Given this list of marker genes NRG3, NLGN4X, TAOK2, NPHP1, PDZD11, CDH22, ABI3, CLDN16, PIP5K1C, SFRP1, EPHA7, HTR4, DST, DLC1 (DLC1 Rho GTPase activating protein), NLGN3, RELN, DRD1, CC2D1A, GPBAR1, ADGRB3, LIN7C, DSG1, C1QL2 (complement C1q like 2), CLASP1, WDPCP, SRGAP2C (NCBI Gene Id 653464), PTK2, PTPN13, POF1B (POF1B actin binding protein), FLRT1, CDH18, DOCK10, DSCAM, CLDN22, NTRK1, TNS1, EPHB2, GABRA1 (NCBI Gene Id 2554), PPM1F, ERBB4, PLXNB2, RAC3, RAP1A, ADGRB2, OPHN1, SRGAP2B, BSN, SMAD3, NPTN, CTNNA1, RAPGEF1, LAMA3, GJA5, SLITRK2, ADGRL2, SLITRK4, S100A10, LIM2, FLRT3, ASIC2, CDH15, KDR, TJP1, GNA13, MIR431, CTNNB1, GABRA6, NPTX1, JAM3, CLDN17, SEMA4D, LIMS1, ADGRB1, PLXNA1, ECT2, TBX5, ANK2, ARHGAP33, PCDHB5, PEAK1, PCDHB16, MYO9A, COL17A1, CLDN2, DBNL, LRIT3, ARHGEF9, SLITRK1, DSG3, CLDN19, NRCAM, VSTM5, ARHGEF15, PPP1R9B, CORO1C, LRRC4B, CLDN11, GPM6B, MARVELD3, NTNG2, SLITRK5, CDC42, GJB1, CD9, PLXNA2, GJA4, GABRA3, CDH2, MIR142, CDH12, CLDN5, MPDZ, FLOT1, FLCN, TLN2, PLXNA3, EPHB3, MYO1C, FKRP, CBLN4, PKP4, GHSR, PTPRK, CAPRIN1, ROCK1, TNF, ACTN1, MMP14, SNCA (NCBI Gene Id 6622), ST8SIA2, RAMP2, RHOG, SPTBN2, FZD5, TSC1, FN1, DOCK4, FAM107A, CLDN8, NCKIPSD, UBE3B (NCBI Gene Id 89910), OCLN, CHD4, PKP3, VEGFA, LRRTM1, SYNDIG1, CNTNAP1, LRRTM3, ZDHHC12, S1PR2, CLDN20, GABRA2, IL1RAPL2, CDH11, CNTN5 (NCBI Gene Id 53942), PARD6B, CLDN23, SRPX2, SLK, FER, MAP1B, GNPAT, NPAS4, PKP2, CNTNAP2, BCR, NRXN1, SH3BP1, MAP4K4 (mitogen-activated protein kinase kinase kinase kinase 4), SORBS1, SPOCK2, GJC1, UGT8, PIP5K1A, TLR2, GABRG3, LIN7B, SLC25A46, EEF2K, ITGB1BP1, PRKACA (protein kinase cAMP-activated catalytic subunit alpha), GJA1, ITGA5, VSIG10, CLDN15, NPHP4, SENP1, LIN7A, GJD3, CLDN25 (claudin 25), C1QL3, GJA10, BDNF, GRM6, ASIC1, CBLN1, PECAM1, PTPRJ, CASKIN1, LRFN3, VCL, THSD1, CDH5, WNT3A, CDH4, APP, CLDN6, GABRB2, SIX4, NTN1, CSMD2, SHANK2, COL16A1, IRX3, IL1RAP, POU4F1 (POU class 4 homeobox 1), CUX2, ACTG1, HIPK1, DUSP22, RAP2A, FSCN1, TEK, OGT, SRF, ABL1, DUSP3, ACTB, PUM2, PTK2B, GABRG1, FZD1, NRP1, ELFN1, NTRK3, PLXND1, CLDN7, RAC1, IL1RAPL1, CDH6, RYK, STON1, MACF1, CFL1, CLDN14, ARHGAP6, CRKL, LINGO4, CLDN4, SNAI2, RTN4 (reticulon 4), NRXN2, MARVELD2, ITGA2, FGF13, AFDN, SLITRK6, MYOC, STRN, SDK1, PTPRA, ACTN2, CLDN34, PCDHB11, NLGN2, CLDN9, GPHN, HRG, PCDHB2, SLIT1, CLSTN3, CAPZA1, PTPRO, F11R, IL1B, GREM1, IQSEC2, CLSTN2, DAPK3, LRRC24, ADD2, MARK1, ACHE (NCBI Gene Id 43), LSR, CLDN10, GPM6A, RAP1B, FBXO45, PTPN1, CLASP2, DKK1, LRRN3, PTEN, DNER, ICAM5, NTRK2, SLITRK3, ACE2, CTTN, MEF2C, CARMIL3, LRP4, TRIP6, AMOT, DMTN, PHLDB2, WHAMM, EFNA5, PCDHB4, TESK2, RAB13, VLDLR, FBF1, ARMCX5-GPRASP2, CDH24, PDCD6IP, EPHA3, LZTS1, EIF4G1, SEMA4A, SEMA4C, CLDN1, SHANK3, NEURL1, SMAD7, GRHL2, CDH3, AJUBA, CAMSAP3, NPHS1, PLXNA4, SLC9A1 (solute carrier family 9 member A1), RPS6, MPP7, CLDN3, CRK, MUSK, SLC39A9, MDGA1, GDF2, VMP1, LRRTM2, LATS1, CDH20, LRRN1, CDK5, CDH19, PLXNC1, WNT7A (Wnt family member 7A), PCDHB6, ITGB4, DVL1, ZDHHC2, FERMT2, LDB1, GAP43, GPRASP3, IKBKB, TBCD, GABRB3, CLDN18, TRPV4 (transient receptor potential cation channel subfamily V member 4), HAPLN4, SRC, NEGR1, RCC2, APLNR, RHOA, MAPT, BCL2, UBE2M, SDC4, GRIA1, NECTIN1, IL17A, GABRE (NCBI Gene Id 2564), ADNP, PTPRD, ROBO2, CRTAC1, GRID2, LIMCH1, APC, CDH13, THBS2, SETD5 (NCBI Gene Id 55209), HDAC7, DRD2, PLXNB3, PLXNB1, MICALL2, LRTM2, VPS35, POLDIP2, SNAI1, EFNB2, ZDHHC8 (NCBI Gene Id 29801), GJB2, RTN4R, STAU2, GPC4, SIX1, PCDHB3, NUMBL, DLG1, CAV1, DOCK1, PLEC, RAB17, MYCBP2, ARL2, LHFPL4, WNT4, CYFIP2, GABRG2, ARHGAP12, DNM3, PRKCH, RAPGEF2, APOD, MIR105-1, NEDD8, THBS1, FRMPD2, WDR1, ADGRL3, ARF6, PKP1, ACTN3, PTPRS, LRFN4, PCDHB9, ESAM, CDH1 (NCBI Gene Id 999), ACE, LGI2, GABRA5, CLDN12, CBLN2, LAMC1, GHRL, LRFN5, CDH10 (cadherin 10), CDH9, EPHA2, LINGO2, FARP1, ADGRF1, OXT, ARHGEF7, SRGAP2, TPBG, CDHR3 (NCBI Gene Id 222256), FLRT2, AGT, AMIGO1 (adhesion molecule with Ig like domain 1), TLN1, PCDHB13, CORO2B, ACVRL1, NLGN4Y, PRKCA, GABRA4, AMIGO2, LRFN1, CRMP1, CHRNB2, NAE1, FGFR1 (fibroblast growth factor receptor 1), PATJ, EPB41L3, EPHB1, WNT5A, OCEL1, CDH17, CRIPT, EPB41L5, PCLO, PRICKLE1, CRB3, CDH26, NR1H4, CLDN24, PCDH17, RAB29, IGSF11, ABI2, AMIGO3, LRRC4, ROCK2, TRIM47, PKN2, SLC12A5 (solute carrier family 12 member 5), PARD3, NLGN1, AGRN (NCBI Gene Id 389836), CLSTN1, ILDR1, THY1, KIRREL3, WNT11, PAK2, JUP (NCBI Gene Id 3728), SIGMAR1, ITGB3, HOPX, CDH8, RHOC, LARGE1, KCNJ8, ITGA6, NECTIN3, DLG5, ZNF703, PCDHB10, MECP2, CDH7, RHOD (NCBI Gene Id 29984), PDLIM5, COLQ, SDK2, GJB6, ELMO1, PCDHB14, here is a description of the gene set: A cellular process that results in the aggregation, arrangement and bonding together of a set of components to form a cell junction. Human Gene Set: GOBP_CELL_JUNCTION_ASSEMBLY species: Homo sapiens